The following is a description of a gene set: species: Mus musculus Mouse Gene Set: TABULA_MURIS_SENIS_LARGE_INTESTINE_SECRETORY_CELL_AGEING from publication Tabula Muris Consortium (PMID 32669714), and this is the list of marker genes: Dynll2, Hnrnpk (NCBI Gene Id 15387), Gpd1, Ctsh, Rnf44, Tssc4, Hnrnpd, Keap1, Fus, Usp22, Ncstn, Zpr1, G3bp1, Mrtfb, Ssbp4, St3gal4, Efhd2, Zfp622, Psmc6, Eif2a, Ptpn1, Exoc7, Tmem109, Pnrc2, Brix1, Rbm3, Dxo, Rfc2, Ppp1r8, Krt19, Rnf126, Ints15, Pkp2 (plakophilin 2), Rdh13, Elof1, Ctbp1, Gmppb, Cfb, Bcl2l1, Wbp2, Ppp1r35, Letm1, Twf1, Nfkbiz, Gsn, Mxd1, Ssr1, Ier2, Ehd1, Brd7, Fkbp8, Acat2, Ptbp1, Lmf2, Psmc2, Ccdc6 (NCBI Gene Id 76551), Hes1, Rrp7a, Ahcy, Ifitm2, Sf3b2, Cct8, Oaz2, Qdpr, Ppif, Swi5, Vamp2, Ddx39a, Fam110a, Sumo3, Lap3, Nucb2, Tmsb10, Noc4l, Ei24, Cnbp, Mllt6, Rrp1, Smpd1, 2310011J03Rik, Smad1, Mcm5 (minichromosome maintenance complex component 5), Rrad, Dedd, Copz1, Sfn, H1f0, R3hdm4, Klf13, Akr1e1, Fam3a, Aldh1b1, Lzts2, Qsox1, Tmub2 (transmembrane and ubiquitin-like domain containing 2), F11r, Capzb, Prelid3b, Smarce1, Tinagl1, Trmt2a, St6galnac4, Furin, Smco4, Alas1, Dcakd, Ccnd1, Rrm1, Anapc5 (anaphase-promoting complex subunit 5), Hipk1, Ssh3, Tox, Mcat, Hnrnpa0, Bop1, Nabp2, Pgk1, Bri3 (brain protein I3), Gadd45gip1, Gspt1, Slc48a1, Nav2 (neuron navigator 2, NCBI Gene Id 78286), Dnajc7, Rbm25, Cd81, Polr3gl, Ctnnbip1, Mpst, Scn1b, Rpl7l1, Atp5mc2, Wdr18, Kmt5c, Vamp3, Klf5 (NCBI Gene Id 75093), Orai1, Steap3, Pdk2, Gnptg, Tfg (NCBI Gene Id 56499), Ddrgk1, Snrpa, Tmed5, Pcnp, Dpf2, S100a14, Bub3, Sox9, Cdc123, Maz, Pick1, Coasy, Mospd3, Cdk5rap3, Ecsit, Tmt1a, Wdr46, Arf1, Polr3d, Kctd5, Cux1, Rbm42, Dvl3, Fen1, Stip1, Krt83, Foxa2, Sap18, Btbd2, Atp6v0c, Cpped1, Gpr180, Dnajb9, Cdk4, Get3, Ccnd3, Tpd52, Aamp, Gadd45b, Idh3a, BC005624, Mtfr1, Aldh9a1, Syt7, Ubl7, Ctsb, Nup62, Atg4b, Tnk1, Cndp2, Chd7, Hid1, Eif2s1, Pfkl, Poc1a, Gga1, Foxa3, Bsn, Srf, Tmem263, Pfn1, Ptov1, Rpl3, Tmem234, Inafm2, Stap2, Sugp1, Fundc1, Abcb8, Htra2, Bcar1, Commd10, Akt1s1, Usp2, Plk1, Slc25a3, Gjb1, Ung, Smarcb1, Tkt, Raly, Irf2bp2, Rnf149, Kdm6b, Atf6b, Cnp, Nkiras2, Psmd12, Tomm70a, Puf60, Bsg, Ptp4a2, Rnf220, Engase, Kdelr1 (KDEL (Lys-Asp-Glu-Leu) endoplasmic reticulum protein retention receptor 1), Laptm4a, Ywhaz, Anapc11, Xpnpep1, Arl1, Cln6, Tpm3, Trf, Aqp1, Sfxn5, Ddhd2, 2610528J11Rik, Hnrnpf, Traf3ip2, Nudt22, Acot8, Arfgef3, Yars1, Emd, Pak4, Preb, Trabd, Cdc37, Ica1, Tysnd1, Nubp2, Rnf166, Fam83g, D630039A03Rik, Rpl13a, Srsf7, Ptpa, Cnppd1, Ush1c, Papss1, Srprb, Ppp4c, Emc10, Arpc4, Snrnp70, Prr13, Endog, Cirbp, Baiap2l2, Farsb, Pnpla2 (patatin-like phospholipase domain containing 2), Stub1, Dusp1, Cnot8 (CCR4-NOT transcription complex, subunit 8), Rab3d, Chmp1a, Txn2, Mmp14, Tomm40, Clcc1, Tbc1d17, Jund, Dda1, Nherf1, Slc9a1 (solute carrier family 9 (sodium/hydrogen exchanger), member 1), Rbm38, Btbd6, Arf5, Lsm2, Rnf187, Dlgap4, Cct6a, H3f3b, Eif4h, Ftsj1, Tsc22d1, Tra2a, Pold4, Arhgdia, Pheta1, Rhoc, Rnf215, Fbl, Ap1ar, Nap1l4, Traf4, Serbp1, Ap2s1, Jpt2 (NCBI Gene Id 69951), Sphk2, Tnfrsf1a, Srrt, Ubald1, Fbxw2, Klf16, Csf2ra, Sil1, Akap8, Nsd3, Fkbp4, Ncln, C2cd4a, Tagap1, Dhrs4, Zfhx3, Gabarapl1 (NCBI Gene Id 93738), Ldlr, Pex14, Mcm6, Rbm26, Clic4, Cops7a, Ewsr1, Usf1, Foxp1, B3gat3, Tmub1 (NCBI Gene Id 80664), Rnpep, Rcc2, Pak1, Cbx5, Rab11b, Ppp5c, Vps72, Trp53, Gadd45g, Nagk, Inpp4a, Nono, Set, Cotl1, Ppm1g, Snrpc, Nim1k, Atp5f1a, Aga, Kansl2, Psap, Ormdl3, Dek, Eif4g1, Grk6, Rab7, Txndc12, Hnrnph3, Ceacam10, Wbp11, Marcks, Rnf10, Etfa, Rusc1, Ep400, Sycn, Dbnl (NCBI Gene Id 13169), Cdca7, Med25, Arl8a, 2410002F23Rik, Elavl1, Vsig2, Vmac, Ino80e, Prr5, Xrn2 (NCBI Gene Id 24128), Rtcb, Tmed9, Ubb-ps, Sf1 (NCBI Gene Id 22668), Kars1, Phf23, Ptpn18, Tmem9, Mcu, Ehd4, Gtf2f1, Arfgap2 (ADP-ribosylation factor GTPase activating protein 2), F8a, Cfdp1, Nectin2, Gar1, Sypl1 (synaptophysin like 1), Mvp (NCBI Gene Id 78388), Sh3gl1, Hdhd2, Hsf1, Max, Cnpy3, Cant1, Ube2l3, Eif3d, Rgmb, Rabl6, Gpsm1, Hnrnpa3, Plpbp, 4933434E20Rik, Prpf19 (NCBI Gene Id 28000), Reg4, Ywhae, Hdgf, Hspa14, Eef1a1, Polr3e, Nucks1, Junb, Abi1, Cnnm4 (NCBI Gene Id 94220), Naa10, Dpysl2, Mark2, Mcm7, Psmc3, Sptssa, Ctbp2, Cdx1, Cct5, Egln2, Eif1a, Upb1, Babam1, Naa80, Slc35a2, Mrpl38, Spsb3, Maea, Hmg20b, Ppp2r5c, Tmem250, Ppp1r2, Tmed4 (NCBI Gene Id 67820), Hspa2, Pgd, Nudt3, Prrg2, Msi2, Esrra, Tnk2, Ivd, Eif5a, Psmc4, Hspa8, Vasp, Cldn14, Srsf5, Fam241b, Itpk1, Nfia, Rad23b, Ybx3, Chtop, Cltb, Rab1b, Bbc3, Exosc5 (NCBI Gene Id 27998), Eif2b4 (eukaryotic translation initiation factor 2B, subunit 4 delta), Vps37b, Rcc1, Tcf4, Tmem161a, Rhoa, Hspa1a, Actl6a, Mbd2, Macrod1, Cd82 (CD82 antigen), Ppp1r16a, Drap1, Lmnb1, Rnaset2b, Ptpro, Shisa5 (shisa family member 5), Rab5c, Armc5, Cdx2, Got2, Dtymk, Psmd3 (proteasome (prosome, macropain) 26S subunit, non-ATPase, 3), Hoxa11os, Pycr2, Ppp1r1b, Mgat1, Txnl4b, Fut2, Tsc22d4, Abcf2, Rtn3, Spop, Ube2m, Bag3, Cd151, Tcea3, Rap1a, Abhd8, Cdv3, Rmdn3, Adrm1, Tmem39a, Mad1l1 (NCBI Gene Id 17120), Gars1, Tcerg1, Dlst, Eif3f, E2f4, Agpat1, Eif3e, Dnaja1, Manbal, Vps37c, Snx17, Snx15, Liph, Ptma, Mboat7, Dusp5, Rsrp1, Paip1, Szrd1, Actr2, Prnp, Slc29a1, Ybx1, Mlf2, Cbx1, Gipc1, Dnajb1, Map2k2, Phb1, Ehbp1l1, Pes1, AW209491, Pisd, Abhd17a, Yy1, Cbs, Rad23a, Eef1g, Trim46, Prkab1, Akt1, Scamp3, Mzt1, Lias, Dusp3, Ube2v1, Psmd4, Irf8, Ppcs, Cpsf6, Calm3, Pebp1, Ssr3, Slc66a3, Csnk2a1, Eri3, Snx1, Sdf2l1 (stromal cell-derived factor 2-like 1), Rpl4, Slc1a5, Ptms, Myc, Ccar1, Stk16, Surf6, Aldh3b2, Egr2, Tcf7l1, Sfxn1, Grb2, Qars1 (NCBI Gene Id 97541), Mpi, Atad3a, Nfic, Psmd13, Pip4p1, Nr1h2, Zfpl1, Tex261, Lypla2, Apobec3, Cracr2b, Dusp6, Csrnp1, Memo1, Gnb1, Gatd3a, Mpdu1, Colgalt1, Arpc1b, C2cd4b, Cfl1, Ppil1, Dapk3, Ltbr (NCBI Gene Id 21932), Ece1, Tlcd3a, Slc30a6, Larp4b, Lrrc8a, Nr2f6, Phb2, Zfp414 (zinc finger protein 414), Pkm, Tor3a, Slc25a10, Spr, Chchd3, Slbp, Zfp787, Arid4b, Sdc1, Frat1, Clic1, Zfp710, Efcab14, Inava, Sh2b1, Nudcd2, Map1lc3a, Mfsd13a, Sf3b4, Lurap1l, Rita1, H2ax, Pold2, Blcap, Mid1ip1, Golt1b, Snrk, Rtkn, B4galnt1, Fbxw8, Fbxw5, Oaz1, Ube2e1, Actr1b, Incenp, Sgta, Csnk1g2, Cnot9, Aifm1, Sdhc, Cgn, Inafm1, Srm, Pdp2, Arfip2, Arl2bp, Crnkl1, Ttc38, Eml2, Rars1, Naa50, BC005537, Bzw2, Klhl22, Npm1, Itm2c, Ddx56 (NCBI Gene Id 68057, DEAD box helicase 56), Tmbim6, Psmd2, Cct7, Gclm, Pla2g2f, Zfp219, Snap23, Hgs, Ruvbl2, Ggt6, Cideb, Tle5, Nt5c3b, Cdk9, Tcf7l2, Nras, Cldn25, Gna11, Dus1l, Gnaq, Zfp36, Dcps, Bdh1, Edem2, Uchl5, Pa2g4 (proliferation-associated 2G4), Pnkp (NCBI Gene Id 76351)